Given this list of marker genes HAUS2, MAGOHB, PRPF4, PTPRD, CHD5, RBPMS, STRBP, ASB8, PRRG1, FOXA1, UBE2G1, ANKMY2, TNN, DUSP6, SOCS5, RALBP1 (NCBI Gene Id 10928), KIF4A, NEDD4, EP300, SGMS1, CBX3, AP5M1, VPS4B, RIOK2, KRTAP4-3, ZBTB44, HHAT, CUL4B, MXD1, KIAA0753, PLCB2, ABI3BP, RIMOC1, ZNF148, GRIA2, PER3, ZNF567, MID1, SLC40A1, CCDC88C, here is a description of the gene set: from publication Chen Y, Wang X (PMID 31504780) Genes predicted to be targets of miRBase v22 microRNA hsa-miR-6826-5p in miRDB v6.0 with MirTarget v4 prediction scores > 80 (high confidence targets). species: Homo sapiens Human Gene Set: MIR6826_5P